Given this list of marker genes FGF18, FGF9, FGF17, FGF2, FGFR3, FGF1, FGF23, FGF5, FGF8, FGF16, FGF4, FGF20, here is a description of the gene set: studied in species Homo sapiens Reactome Pathway: FGFR3 mutant receptor activation part of: Signaling by FGFR3 in disease The FGFR3 gene has been shown to be subject to activating mutations and gene amplification leading to a variety of proliferative and developmental disorders depending on whether these events occur in the germline or arise somatically. As is the case for the other receptors, many of the activating mutations that are seen in FGFR3-related cancers mimic the germline FGFR3 mutations that give rise to autosomal skeletal disorders and include both ligand-dependent and independent mechanisms. In addition to activating mutations, the FGFR3 gene is subject to a translocation event in 15% of multiple myelomas. This chromosomal rearrangement puts the FGFR3 gene under the control of the highly active IGH promoter and promotes overexpression and constitutive activation of FGFR3. In a small proportion of multiple myelomas, the translocation event is accompanied by activating mutations in the FGFR3 coding sequence.<br>Finally, FGFR3 is subject to fusion events in a number of cancers, including lung, bladder and glioblastoma. These fusions are constitutively active based on dimerization domains provided by the fusion partners and support transformation and proliferation through downstream signaling pathways such as ERK and AKT.